Given this list of marker genes Btla, Arid1a, Tbk1, Kctd9, Pbrm1, Ifnz, Rpl22, Il1rl2, Smad7, Cd83, Flt3, Dcaf1, H2-DMa (NCBI Gene Id 14998), Ncaph2, Smarca4, Pdcd1lg2, Hes1, Pag1, Pknox1, Treml2, Slc39a10, Grb2, Zfp335, Stat5b, Pibf1, Kcnk18, Flt3l, Vsig4, Fbxo7, Nhej1, Ptcra, Cdkn1a, Ccr7, Onecut1, Jak2, Foxp1, Dusp22, H2-DMb1, Ighm, Phf10, Psg17, Foxj1, Fgr, Dapl1, Ceacam1, Xrcc6, Mfng, Atg5, Cxcr4, Ptk2b, Spi1, Wnt10b, Smarce1, Il12b, Tnfsf13, Phf14, Sftpd, Myh9, Tnfsf18, Itfg2, Tnfsf11, Hells, Kat7, Mertk, Id2, Cd1d2 (CD1d2 antigen), Igfbp2 (NCBI Gene Id 98288), Psg21, Hfe, Cd24a, Ifna5, Msh2, Tnfrsf14, Emp2, H2-Eb1, Zc3h8, Scart2, Cd59b, Ccl2, Tlr4, Inpp5d, Hsp90aa1, Sos1, Irs2 (NCBI Gene Id 384783), Foxn1 (NCBI Gene Id 51955), Rag2, P2rx7, Ephb1, Psg28, Gadd45g, Brd2, Il12a, Tfrc, Cd276, Cd79b, Prnp (prion protein), Aplf, Srf, Aif1, Mir19a, Pglyrp1, Rasal3, Hprt1, Igbp1, Itgax, Lef1, Tbc1d10c, Nkg7, Csk, Trex1, Cd8a, Ccl19-ps1, Rag1, Gpnmb, Tnfsf8, Usp44, Rbx1-ps, Drosha, Rasgrp1 (NCBI Gene Id 19419), Pbx1, Prkdc, Clec2i, Mir301, Jaml, Mad2l2, Atp7a, Cdk6, Tsc1, Zbtb7a, Stx11, Ifna12, Mir20a, Flot2, Hmgb3, Igkj5, Ceacam12, Chrnb2 (cholinergic receptor nicotinic beta 2 subunit), Fosl2, Bst1, Gpr89, Pou2f2, Smarcc1, Psmb11, Ticam1, Mettl3, Ada, Braf, Nfil3, Gm13271, Itm2a, Smarcd3, Exo1, Dock10, Hhex, Traf6, Il27ra, Prlr, Prex1, Ager, Mink1, Pik3r6, Bcl3, Zfp35, Ccl19-ps4, Gm36723, Jmjd6, Gm13275, Dnaja3, Cd59a, Rsad2 (NCBI Gene Id 72445), Dusp3, Paxip1, Nckap1l, Gpr18, Rorc, Itgam, Unc13d, Gm13277, Ifna15, Git1, Irf2bp2, Cebpb (CCAAT/enhancer binding protein beta), Lag3, Zfp609, Bad, Stat4, Shld1, Myc, Atp11c, Pik3cd, Ufl1, Spn, Sh2b3, Cxadr, Ncor1, Mill1 (NCBI Gene Id 266815), Cd2ap, Phb2, Fcgr4, Ifna9, Tnip2, Ddrgk1 (NCBI Gene Id 98926), Blm, Klhl25, Lgals8, Bloc1s3, Exosc6, Blnk, Ccl19-ps5, Zc3h12d, Relb, Ccl19-ps3, C3, Dusp10, Rbpj, Cd81, Hectd1, Ezh2, Gm13283, Fanca, Icosl, Rabl3, Ctsl, Tcirg1, Fkbp1a, Ccdc88b, Cd55b, Mpl, Slamf9, Ido1, Fas, Fzd8, Il27, Cd209c, Jag2, Il6ra, Ambra1, Epo, Runx3, Slc25a5, Men1, Clec12a, Mir150, Trem2, Wdfy4, Malt1, Gimap3, Lgals1, Myb, Axl, Rab27a, Gon4l, Ccl21b, Il7, Il9r, Mir326, Nlrp3, F2rl1, Clnk, Ifna11, Impdh1, H2-Ab1, Lamp1, Siglecg, Spta1, Rac2, Tac1, Gli3, Cd55, Klrb1c, Vcam1, Fgl1, Itgav, Akirin2, Tnfsf13b, Lat, Lig4, Mir19b-1, Tshr, Il36b, Tnfsf4, Psmb10, Lgals9, Slamf6 (SLAM family member 6), Bmp4, Sfrp1, Sanbr, Zap70, Plcg2, Itgad, Ppp2r3c, Lck, Kmt2a, Psg25, Cd300a, Prf1, Actb, Pla2g2d, Slc15a4, Tigit (T cell immunoreceptor with Ig and ITIM domains), Tusc2, Dll4 (NCBI Gene Id 54485), Il10, Cd38, Hspd1, Cd74, Washc1, Ighe, Rps3, Smarcb1, Cgas, Card11, Smarcd1, Zbtb1, Cyld, Il6st, Ephb6, Ceacam14, Il2rg, Slamf7, Btk, Prelid1 (PRELI domain containing 1), Bak1, Sp3, Mr1, Slc39a6, Ikzf1, Pla2g5, Cd6, Igf2, Brd7, Lilrb4a, St3gal1, Marchf7, Mapk8ip1, Rara, Mir181b-1, Laptm5, Hps1, Hdac7, Bmi1, Ifna1, BC037156, Gimap1, Xrcc4, Il15ra, Ripor2, Selenok, Dcaf12, Polm, Cd3d (CD3 antigen, delta polypeptide), Rassf5, Alkbh5, Cd79a (NCBI Gene Id 12518), Slamf1, Mafb, Dlg5, Lipa, Ins1, Ifnb1, Peli1, Tnfsf14, Cd3g, Aire, Swap70, Tmem98, Abl2, Sox11, Irf4, Clec4g, Dnajb9, Slc4a1, Shld3, Ptprc, Il1b, Pf4, Hmga1, Lrrc32, Fancd2, Adam17, Sox12, Arid2, Mir17, Icos, Fnip1, Gm11690, Ifna13, Hotairm1, Ntrk1, Runx1, Stk11, Skint1, Rnf168, Raet1d, Pla2g2a, Bcl2, Bloc1s6, Runx2, Tmem131l, Ccl19, Kat5, Il20rb, Tnfrsf4, Armc5, Tgfbr2, Plxna1, Socs1, Kat2a, Mad1l1, Nfatc1, Gja1, Tespa1, Trp53bp1, Il12rb1, Cxcl12, Cd40, Pou1f1, Clcf1, Kdelr1, Tarm1 (NCBI Gene Id 245126), Spib, Ihh, Actl6b, Cd48, H2-Ea, Adora2a, H2-M3, Ctsg, Cul4a, Nkx2-3, Pax1, Gba1, Rps6, Hmgb1, Mpzl2, Nck2, Cd44, Nck1, Ins2, Mzb1, Cd47, Batf, Elf4, Dock11, Cracr2a, Ctla4, Mmp14, Nfatc3, Igf1, Il23a, Pglyrp2, Mlh1, Prr7, Kmt5b, Cfb, Pagr1a, Gal, Nlrc3, Btnl2, Rbx1, Hdac5, Vtcn1, Btn2a2, Ifna2, Itch, Il6, Zeb1, Ighd, Arg2, Fkbp1b, Eomes, Xcl1, Actl6a, Kit, Ccr9, Rnf8, Brd4, Ccl19-ps6, Rc3h2, Atf2, Ankle1, Cd320, Tlr9, Psen1, Phb1, Bcl2a1d, Tcf7, Cd151, Traj18, Thy1, Clec7a, Ncstn, Il9, Otud5 (OTU domain containing 5), Ap3d1, Cebpg, Ccr2, Efnb3, Fzd5, Ifne, Mir873a, Tacr1, Itgb6, Zmiz1, Ppp3ca, Cd70, Vav3, Dhps, Mir18, H2-Oa, Cav1, Nedd9, Aqp8, Traf3ip2, Cd8b1, Wwp1, Ms4a1, Atad5, Themis2, Csf1r, Pglyrp4, Ifnar2, Shh, Hs1bp3, Nfam1, Il18r1, Bank1 (B cell scaffold protein with ankyrin repeats 1), Tyro3, Tpd52, Mdk, Havcr2, Ceacam13, Vpreb1a (NCBI Gene Id 22362), Cacnb4 (NCBI Gene Id 73120), Tnfrsf1b, Ephb2, Pycard, Cd180, Cdh26, Gata3, Irf1, Sh2d2a, Arg1, Was, Exosc3, Cbfb, Loxl3, Il2, Skap2, Satb1, 6030468B19Rik, Fcer1g, Clec4a2, Pdcd1, Fbxo38, Pck1, Cd209d, Stoml2, H2-Eb2, Mir92-1, Egr1, Tnfrsf13c, Ccl21d, Ep300, Foxp3, Slc39a7, Ikzf3, Sit1, Cr2, Ncr3-ps, Cd86, Lfng, Cd40lg, Fzd7, Ppp3cb, Rora, Lmo1, H2-Aa, Scgb1a1, Cblb, Cd209a, Slc4a2, Cd2, Pik3r1, Kitl, Hdac9, Cd3e, Il3, Klrk1, Prkaa1, Lep, Nrarp, Lyn, Crip3, Kmt5c, Chrna7, Sh3rf1, Ephb4, Top2b, Rc3h1, Carmil2, Sox4, Crtam, Ifna14, Cd209e, Ceacam23, Cdh17, Ccl21e, Wnt1, Dtx1, Cd46, Vnn1, Psap, Aicda, Rhoa, Klre1, Lcp1, Slc7a1, Lilrb4b, Mef2c, Pou2af1, Tyk2, Sema4a, Nfkbiz, Coro1a, Cd37, Pkn1, Il1a, Il4, Ly6d, Bcl6, Msn, Zbtb32, Clec4a3, Cd1d1, Ung, Entpd7, Ulbp3 (NCBI Gene Id 215728), Cd22, Msh6, Stat6, Cxcr5, Sdc4, Adrm1, Dpp4, Bcl11b, Plcl2, Btnl1, Ccl5, Fadd, Psg23, Ccnd3, Azi2, Zfp36l1, Mir181b-2, Itpkb, Fzd9, Patz1, Ifna7, Ctla2a, Prkcb, Scrib, Itgal, Tnfrsf21, Nod2, Atm, Il4ra, Il11ra1, Supt6, Hsph1, Nedd4, Lyst, Notch2 (NCBI Gene Id 99749), Ccl21a, Sox13, Ceacam5, Ripk2 (NCBI Gene Id 70170), Ptpn6, Eif2ak4, Ifna4, Ifna6, Ptpn22, Ahr, Pde5a, Tnfrsf13b, Clptm1, Lgals3, Zfp608, Dock2, Lat2, Icam1, Fcrl1, Erbb2, Dicer1, Cd274, Hmces, Pla2g2f, Apc, Prkcz, Ifnk (interferon kappa), Cd84, Themis, Trp53, Zbtb7b, Sla2, Myd88, Igbp1b, Ap3b1, Itk, Hspb1, Bag6, Apbb1ip, Ptprj, Adk, Ifnab, Psg27, Wnt3a, Lrrc8a, Zfp683, Gapt, Slamf8, Ccl20, Vpreb1b, Foxo3, Tirap, Samsn1, Ceacam15, Abcc1, Ighg1, Clec4d, Ap1g1, Znhit1, Sash3, Gas6, Ildr2, Sos2, Pawr, Duxbl1, Efnb2, Pcyt1a, Igkc, Lst1, Ly9, Ifnar1, Il13, Tnfrsf9, Abl1, Prkcq, Btnl6, Fut7, Sirpa, Fgl2, Smarcc2, Ulbp1, Fgf10, Clec4e, Ifna16, Wnt4, Yy1, Syvn1, Tspan32, Shb, Zp3, Gm13276, Cd27, Nsd2, Jak3, Il2ra, Itgb2, Rhbdd3 (NCBI Gene Id 279766), Zc3h12a, Nr5a2, Bcl10, Gpam, Casp3, Hsh2d, Lepr, Irgm1, Enpp1, Il7r, Lax1, Prkar1a, Gsn, Cyrib, Clec4f, Bid, Slfn1, Gm13272 (NCBI Gene Id 545648), Mtor, Ebi3, Itpripl1, Fcho1, Klrd1, H2-DMb2, Gpr183, Vav1, Fcgr2b, Il18, Gimap5, Ptpn2, Hlx, Parp3, Pcid2, Opa1, Psg19, Vsir (V-set immunoregulatory receptor), Il5, Slc11a1, H2-T23, Ifng (interferon gamma), Socs6, Cyp26b1, Tyrobp, Txlna, Ddost, Lmbr1l (NCBI Gene Id 74775), Syk, Cd244a, Gnrh1 (NCBI Gene Id 239161), Tnfaip3, Klhl22, Chrna4, Ceacam3, Pten, Adam8, Pglyrp3 (NCBI Gene Id 242100), Psg26, Sh3kbp1, Ccl21f, Anxa1, Prdx2, Chd7, Tcf3 (transcription factor 3), Glmn, Ascl2, Cd4, Dll1, Il15, Prdx1, Traf2, Shld2, Sh2d1b2, Zfp36l2, Sema6d, Pms2, Stat3, Tnfsf9, Rif1, Il21, Gps2, Smad3, Mif, Xbp1, Prdm1, Psen2, Twsg1, Adgrg3 (adhesion G protein-coupled receptor G3), Rab29, Nbn, Impdh2, Tgfb1, Ctps1, Lyl1, Cd28, Nkap, Pfdn1, Efnb1 (ephrin B1), Psg16, Socs5, Tox, Bax, Dcaf15, Pura, Itgb8, Rhoh, Sart1, Muc19, Fyn, Pnp, Dlg1, Tsc2, Nfatc2, Prkcd, Nfkbid, Ripk3, Slfn2, Dock8, Ercc1, Slc46a2 (NCBI Gene Id 80480), Cd69, H2-Ob, Ccr6, Dclre1c, Ywhag, B2m, Ptger4, Txk, Cd80, Egr3, Smarca2, Cmtm7, Bcl11a, Tbx21, Ndfip1, Il4i1, Ceacam11, Irf8, Sh2d1a, Cdkn2a, Cd5, Clec4a4, Cd19, Stat5a, Rnf41, Smarcd2, Cd160, Ctnnb1, Igtp (interferon gamma induced GTPase), Tnfaip8l2, here is a description of the gene set: Mouse Gene Set: GOBP_LYMPHOCYTE_ACTIVATION A change in morphology and behavior of a lymphocyte resulting from exposure to a specific antigen, mitogen, cytokine, chemokine, cellular ligand, or soluble factor. species: Mus musculus